Given this list of marker genes IFNGR2, IFNAR1, IFNAR2, IFNGR1, IL22RA1, here is a description of the gene set: Human Gene Set: GOMF_INTERFERON_RECEPTOR_ACTIVITY studied in species Homo sapiens Combining with an interferon and transmitting the signal from one side of the membrane to the other to initiate a change in cell activity.